Given this list of marker genes ZNRF1, NCK1, ARAP1, CLCN5 (NCBI Gene Id 90056), RAN, ODF4, P2RY2, TLR6, RIPK3, NUBP2, CA8, GORASP2, CAPZA1, TARS1 (threonyl-tRNA synthetase 1), SEPTIN7, EPRS1, SAV1, HEATR6, FAM32A, PDZD11, FPR1, CABP2, LCK, TNIP2, ETF1, GMFG, MAPRE1 (microtubule associated protein RP/EB family member 1), CNOT7, POFUT2, MEFV, LDLR, RAP1GDS1, ATG3, NAB2, ELAVL1, GUCA2B, ARMH4, PGLYRP2, ETV6, TRAPPC4, KCTD5, PEAR1 (NCBI Gene Id 375033), SECISBP2L, LSM4, CCDC115, PRPF38B, KISS1R, RAMP2, ACTR1A, STX12, ZNF639, DDIT4, RNF14, CDC42SE1, PAX3, JAG1 (NCBI Gene Id 3715), FOXK2, TMEM63A, IGFBP5, SNF8, ERO1A, BYSL, ALG9, NXT1, STRN4, RND3, CHRNA1, SH3BP1 (NCBI Gene Id 84161), KHDC4, COMMD7, GARS1, CD38, MT2A, CRK, MRPL45, GTF2A1, ARPC5, SMIM30, MRPL52, MTMR6, EMID1, NCOA5 (nuclear receptor coactivator 5), HSPA5, IGFBP6, ALX3, RBPMS2, FOXN2, IKBKE, CPA2 (NCBI Gene Id 136262), SPIDR, SLC6A3, PSMD7, CSF3R, CAMKK2, DSCAM, NDEL1, ZNF654, DUSP2, FMR1, IDNK, NECTIN3, MYO1H, TSR1, SIGLEC7, TNNT2, MTMR14, MSN, IL1B, CHORDC1, PIN1, TAC1, MMP13, BLOC1S3, TMEM119, DYNLL1, STAG1 (NCBI Gene Id 10274), TOX4, NEUROG1, IKZF4, GLIPR2, TRAPPC13, NOL12, PROSER1, GTF2F1, ARVCF, NOP56, CIAO2B, CCL4, TRA2B, CLEC4A, PRSS42P, IARS1, KICS2, NEK6, CASP4, RLF, TNFRSF9, TTC1, PGK1, SPRED1, PGK2, ARF6, HP, PHGDH, STK17B, SAMD4B, MARCKSL1, HOXB2, TMEM116, APBA3, ZFAND3, CRHR2, PSPC1, PRKG2, SEPTIN11, ST3GAL1, VAPA, EFNA5 (NCBI Gene Id 1946), LYN, PDK1, C5orf24, TRPS1, SUPT6H, ZBTB7B, KRCC1, RAB20, IFNAR1 (NCBI Gene Id 3454), RBM22, MC3R, NECAP2, PGP, TPM3, CDS2, SEMA3F, YARS1, CCL2, SEC24B, PHLDA1, ZNF292, IST1, SF1, AP2S1, NUPR1, SP2, OPRL1, SEC11A, RRAD, IDH3A, RWDD4, MED14, VSTM2A, SLC16A1, SUN1, TRAPPC14, GDPD1, ITGB1, RNF149, TANK, MED29, PYCARD, here is a description of the gene set: Human Gene Set: GSE23308_WT_VS_MINERALCORTICOID_REC_KO_MACROPHAGE_CORTICOSTERONE_TREATED_DN Inappropriate excess of the steroid hormone aldosterone, which is a mineralocorticoid receptor (MR) agonist, is associated with increased inflammation and risk of cardiovascular disease. MR antagonists are cardioprotective and antiinflammatory in vivo, and evidence suggests that they mediate these effects in part by aldosterone- independent mechanisms. We used affymetrix to characterize the effect of Mineralocorticoid Receptor deletion on macrophage transcriptional profile, and identify its requirement in normal glucocorticoid signalling. from publication Usher MG, Duan SZ, Ivaschenko CY, Frieler RA, Berger S, Schütz G, Lumeng CN, Mortensen RM (PMID 20697155) studied in species Homo sapiens Genes down-regulated in macrophages treated by corticosterone: wildtype versus NR3C2 knockout.